Given this list of marker genes SIX1, RECK, TSPAN14, ETV6, PGS1, RABGAP1L, UNC79, FAM241A, BCL2, CSTF1, EXOSC5, CCR7, POLR3E, TBC1D5, CD96, CXCR5, PCCA, YDJC, RRAD, MRPS34, CASP4, TRMT61A, ZNF296, DGKA, LEF1, ACBD6, SLC26A11, TTC39C, SMAD1, PDLIM1, DENR, DUS2 (NCBI Gene Id 54920), PACSIN1, TBL1X, TDRP, NUDT14, ARMCX2, PLEKHA1, ADCK5, RESF1, IL16, SOD2, WDR11, RIOX1, FOXO1, TEC, RFLNB, IL27RA, ADAR, MRPL23, CCNY, ENTPD5, SLC11A2, MCFD2, PFDN2, PIP4K2A, GLRX5 (glutaredoxin 5), USP24, MRM3, IFNAR2, RPS18, MYBBP1A, PRXL2A, TRIB2, MAP4K3, RPL32, BCL2L11, SCARB2, NEIL1, TSR1, PMM2, IGF2BP2, CTSS, ABCG1, RETREG1, QNG1, HSDL2, TSR2, CFAP97, TRIM5, SPINT2, RWDD1, CTSZ, SESN3, TOM1, WDR12, WDR74, THADA, PDK1, SFT2D2, ABHD8, TIGAR, PTPN3, CCR6, SESN1, ACOT13, DPH7, SLAMF6, ARFGAP2, SIPA1, SLFN13, PVT1, CYP4V2, MTLN, TDRD3, IKBKE, NOP53, HLA-DOA, SKIL, DDB2, NOA1, N4BP2L1, JAK3, TFE3, CREB3, HSPE1, SDF4, GRK6, PCGF6, ARHGAP9, ZEB1, OAS1, UTP4, ICOS, NKAPD1, CYB5A, RPS19, RPUSD2, MCOLN3, DTD1, ZCCHC2, TSPAN13, RAI1, DNMBP, IARS1, TAPBPL, RNF19B, IMMP2L, MTR, CD2AP, MCEE, PARP3, ECE2, RAB20, LYPD6B, URB1, DNAAF10, P4HTM (NCBI Gene Id 54681), TOR1AIP1, DKC1, LSM7, MYC, EEIG1, FASTKD2, RPAP2, MRI1, MCOLN2, CD9, FAAH, EMB, VPS13A, PDE2A, FCHSD2 (NCBI Gene Id 9873), CCS, CNP, RELB, ORAI1, ID3, XRCC5, CALHM6, PDE4B, CFAP298, GDPD5, YARS2, LTA, BTLA, NIT2, UTP11, CRTAM, TAF4B, PPP1R17, HDDC2, TACC2, THUMPD2, KDSR, FBXO21, PPIL2, FAM78A (NCBI Gene Id 89854), ADI1, STIM2, NEK7, HINT2, HINT3, UBASH3A, GEMIN4, DPY19L3, RANBP10, TRAF5, ZFYVE1, here is a description of the gene set: At the peak of the CD8 T cell response to acture viral and bacterial infections, expression of the Interleukin-7 Receptor (IL-7R) marks Memory Precursor Effector CD8 T Cells (MPECs) from other Short-Lived Effector CD8 T cells (SLECs), which are IL-7Rlo. This study was designed to determine the gene expression differences between these two subsets of effector CD8 T cells. species: Homo sapiens Genes down-regulated in IL7R low effector CD8 T cells versus IL7R high effector CD8 T cells. Human Gene Set: GSE8678_IL7R_LOW_VS_HIGH_EFF_CD8_TCELL_DN from publication Joshi NS, Cui W, Chandele A, Lee HK, Urso DR, Hagman J, Gapin L, Kaech SM (PMID 17723218)